Given this list of marker genes Vamp5, Neu1, Cplx2, Tc2n (tandem C2 domains, nuclear), Mycbp (MYC binding protein), Zfp971, Pirt, Elovl5, Zfp91, Dera, Napb, Stard8, Pafah1b1, Amotl1, Xlr, Larp4, Fech, Atrx, Retn (resistin), Sowahc, Pgap1, Extl3, P4ha3, Aldh1l2, Chml, Cd4, Cipc, Crkl, Inhbb, Rock2, Klhl13, Arhgef9, Acbd5, Vegfa, Krtap4-13, Arpp21, Prkcd, Lhfpl6, Nfat5 (NCBI Gene Id 54446), Syn3, Prlr, Timm21, Acvr2b, Setd3, Enpp1, Trmt2b, Adcy9, Lamp2, Adcyap1, Gpm6a, Zfp46, Ap1ar, Rab9b, Vapb, Cd33, 2210418O10Rik, Idh3b, Cstf3, Gpr132 (NCBI Gene Id 56696), Gcnt2, Them7, Pou4f2, Zfp729b (zinc finger protein 729b), Rbms3, 3425401B19Rik, Trpc6 (transient receptor potential cation channel, subfamily C, member 6), Slco3a1, Pla2r1, Pdzrn4, P2rx7, Slco2a1, AI429214, Rspo1, Sh3bgrl2, Sh2d2a, Zfand3, Zfp931, Gm14296, Klf6, Tcte1, Adgra1, Cgas, Irag1, Cckar, Bean1, D630023F18Rik, Fmn2, Ssbp4, Mylk4, Triobp, Insyn2a, Mmp20, Fezf1, Adal, Gm2026, Gria3, Brwd3, Pfkfb2, Musk, Iars1, Xrcc3, Tmem47, Tesmin, Zfyve16, Pck2, Kpna3, Sh3rf3, Vsig10l, Tead1, Onecut3, Tmem144, Plac9, P2ry13, Nlgn3, Zfp595, Gabrb3, Acot3, Spr, Armc1, Fsd1l, Abraxas1, Kpna1, Rbpms, Rslcan18, Cat, Vps33b, Gtf2h2, Ints8, Tmem196, Il1rap, Septin3, Fam180a, Sox5, E2f8, 4930523C07Rik, Adgrf5, Lcn10, Papss2, Lnx2, Ttc9 (tetratricopeptide repeat domain 9), Slco2b1, Zfp92, Kcne2, Treml2, Ttc39a, Prc1, Cps1, Nr3c1, Camta1, Cdcp3 (NCBI Gene Id 71395), Fbxo43, Elfn1, Gm14325, Kansl1l, Stox2, Iglon5, Pcsk2, Pou3f4, Tcaf2, Trim12c, Nol12, Scfd1, Krtap4-21, Gxylt1, Map10, H13, Mill1, Nhsl2, Car10, Nox4, Eda2r, Epas1, Rdh19, Il18r1, Oxgr1, Zfp935, Enpp6, Gm9, Gnb4, Olr1, Slc6a19, Map3k20, Star, Pstpip2, Uck2, Ccpg1, St18, Zfp516, Tasp1, Rsph4a, Gatc, Zfp1009, Pcmtd1 (NCBI Gene Id 71455), Hexim1, Rgs17, Dusp7, Chmp1b, Septin10, Sema3a, Fgf14 (fibroblast growth factor 14), Tshz1, Tcp1, Zfp936, Fam169b, Nectin1, Dmrtc1a, Arhgef10, Gcnt4, Itga4, Elovl6 (ELOVL fatty acid elongase 6), Rab7, Krtap4-20, Gimap9, Rab11fip1, Foxp3, Gpr82, Cop1, Onecut2, Atrn, Ccdc93, Pitpnb, Enpp2, Lck, Etf1, Bach2 (BTB and CNC homology, basic leucine zipper transcription factor 2), Phf20l1, Scai (NCBI Gene Id 99056), Chst11, Ano3, Galnt13, here is a description of the gene set: Mouse Gene Set: MIR_1187 from publication Chen Y, Wang X (PMID 31504780) species: Mus musculus Genes predicted to be targets of miRBase v22 microRNA mmu_miR_1187 in miRDB v6.0 with MirTarget v4 prediction scores > 80 (high confidence targets).